Given this list of marker genes NDC80 (NDC80 kinetochore complex component), CAV1, CALD1, ANTXR2, BTN3A2, BTN3A3, TGFBR2, LYN, RIPK4, ELL2, NNMT, MET, SH3KBP1 (SH3 domain containing kinase binding protein 1), PPP1R18, DCBLD2, AKR1C3, F3, MAP7D1, TGFBI, LAMB3, GNG12, SOCS5, DENND2B, EXT1, ZNF559 (NCBI Gene Id 84527), COTL1, ZYX, UPP1, ARHGAP29, PCDH7, IFIT3, FSTL1, DUSP10, JAG1, POPDC3, DPYD, TFPI, PGM1, CAST, IL15RA, P3H2, OSMR, SAMD9L, EPHB2 (EPH receptor B2), LARP6, CDC42EP3, REXO2 (RNA exonuclease 2), IFI16, F2RL1 (NCBI Gene Id 7901), CAVIN1, ANXA1, MAML2, PARVA, EGFR, ITGA5, INPP1, SNAI2, PALM2AKAP2, MYO10, CAV2, EPHA2, RAI14, PLAU, FXYD5, PRNP, CCDC50, PDGFC, TNFRSF21, LIMA1, PSMB9, UBE2E3, AGPS, RAC2, PSMB8, ELK3, GBP3, MSN, LAYN, COL5A1 (NCBI Gene Id 1289), KCTD12, here is a description of the gene set: Human Gene Set: HUANG_DASATINIB_SENSITIVITY_UP species: Homo sapiens from publication Huang F, Reeves K, Han X, Fairchild C, Platero S, Wong TW, Lee F, Shaw P, Clark E (PMID 17332353) Genes whose expression positively correlated with sensitivity of breast cancer cell lines to dasatinib. Dasatinib is a multitargeted kinase inhibitor that was recently approved for the treatment of chronic myelogenous leukemia and Philadelphia chromosome-positive acute lymphoblastic leukemia with resistance or intolerance to prior therapy. It is also in clinical trials for treating patients with solid tumors. The identification of molecular markers predictive of response to dasatinib could assist in clinical development by selecting patients most likely to derive clinical benefit. Using baseline gene expression profiling of a panel of 23 breast cancer cell lines, we identified genomic signatures highly correlated with in vitro sensitivity to dasatinib. The ability of these signatures to predict dasatinib sensitivity was further confirmed and validated in independent test cell lines. A six-gene model was used to correctly predict dasatinib sensitivity in 11 out of 12 (92%) additional breast and 19 out of 23 (83%) lung cancer cell lines. Quantitative real-time PCR and immunohistochemical assays further confirmed the differential expression pattern of selected markers. Finally, these gene signatures were observed in a subset of primary breast, lung, and ovarian tumors suggesting potential utility in patient selection. The subset of breast cancer patients expressing the dasatinib-sensitive signature includes a distinct clinical and molecular subgroup: the so-called triple negative (i.e., estrogen receptor-negative, progesterone receptor-negative, and HER2-negative) or basal breast cancer subtype. This patient population has a poor prognosis and currently has few effective treatment options. Our results implicate that dasatinib may represent a valuable treatment option in this difficult-to-treat population. To test this hypothesis, clinical studies are now under way to determine the activity of dasatinib in these patients.